The following is a description of a gene set: Any process that stops, prevents, or reduces the frequency, rate or extent of single stranded viral RNA replication via double stranded DNA intermediate. Mouse Gene Set: GOBP_NEGATIVE_REGULATION_OF_SINGLE_STRANDED_VIRAL_RNA_REPLICATION_VIA_DOUBLE_STRANDED_DNA_INTERMEDIATE studied in species Mus musculus, and this is the list of marker genes: Tasor, Morc2b, Mphosph8, Morc2a (NCBI Gene Id 74522), Apobec3, Setdb1, Aicda (NCBI Gene Id 11628), Hmga2, Trim28, Zfp809, Inpp5k